Given this list of marker genes Cacng8, Shisa7, Flot1, Adrb2, Map1a, Sqstm1, Exoc4, Ophn1, Il1r1, Ctnnb1, Myo5b, Flot2, Igsf11, Cacng3, Pten (NCBI Gene Id 70161), Cacng4, Shisa6, Neto2, mt-Nd2, Grin2b, Dlg4, Cacng2, Nsf, Shank3, Nsg1, Eml2, Canx, Gsk3b, Ube2i, Pias3, Grin1, Rapsn, Drd2, Sdcbp, Gria1, Neto1, Shank2, Agap2, Grip1, Dlg3, Cdk5r1, Gria2 (NCBI Gene Id 14800), Nedd4, Pick1, Fus, Gnas, Snx27, Shank1, Dlg1, Dlg2, Gripap1, Oxtr, Rab4a, here is a description of the gene set: Mouse Gene Set: GOMF_IONOTROPIC_GLUTAMATE_RECEPTOR_BINDING Binding to an ionotropic glutamate receptor. Ionotropic glutamate receptors bind glutamate and exert an effect through the regulation of ion channels. studied in species Mus musculus